Given this list of marker genes CDKN2A, CDK4, CDK6, here is a description of the gene set: species: Homo sapiens Reactome Pathway: Evasion of Oncogene Induced Senescence Due to Defective p16INK4A binding to CDK4 and CDK6 part of: Evasion of Oncogene Induced Senescence Due to p16INK4A Defects Missense and nonsense mutations in the CDKN2A gene that result in amino acid substitutions in p16INK4A or p16INK4A truncations, impairing its ability to bind to CDK4 and CDK6, interfere with p16INK4A-mediated induction of cellular senescence in response to oncogenic signaling.<br>Loss-of-function mutations in p16INK4A can also contribute to cancer by interfering with p16INK4A-mediated inhibition of NFKB signaling.